The following is a description of a gene set: part of: PTEN Regulation Reactome Pathway: Regulation of PTEN localization This event has been computationally inferred from an event that has been demonstrated in another species.<p>The inference is based on the homology mapping from PANTHER. Briefly, reactions for which all involved PhysicalEntities (in input, output and catalyst) have a mapped orthologue/paralogue (for complexes at least 75% of components must have a mapping) are inferred to the other species. species: Mus musculus electronically inferred by orthology from the curated human pathway, and this is the list of marker genes: Ubb, Rps27a